The following is a description of a gene set: from publication Chen Y, Wang X (PMID 31504780) studied in species Mus musculus Genes predicted to be targets of miRBase v22 microRNA mmu_miR_453 in miRDB v6.0 with MirTarget v4 prediction scores > 80 (high confidence targets). Mouse Gene Set: MIR_453, and this is the list of marker genes: Dgkk, Chchd3, Oca2, Lrrn3, Mplkip, Rcor1, Arhgef15, Man1a2, Tmem243, Sntn, Spry2, Akirin2, Ntf5, Sord, Adam12, Tg, Nudt16l1, Slc9a4, Entpd7, Rab2a, Nrdc, Dab1, Cd24a